Given this list of marker genes Gm36584, Or6f1, Cfap161, Vmn2r-ps67, Gm6112, Bnc1, Zfp592, Gm18806, Vmn2r-ps84, Sh3gl3, Gm7964, Gm22177, Gm6230, Vmn2r-ps72, Vmn2r-ps76, Tmc3, Or14a259, E230029C05Rik, Vmn2r66, Gm44968, Zscan2, Ctxnd1, Gm26708, Vmn2r-ps79, Gm19203, Fsd2, Rab38, Homer2, Vmn2r-ps73, Vmn2r-ps78, Or5ae1, Or14c43, Me3, Efl1, 4933406J10Rik, Gm18358, Vmn2r78, Tprgl-ps1, Folh1, Or14a258, Vmn2r-ps66, Vmn2r79 (vomeronasal 2, receptor 79), Gm6240, 2310044K18Rik, Or14c45, Tmem135, Or5ae2, Grm5, 2900076A07Rik, Il16 (interleukin 16), Gm32850, Or14c41, Gm18359, Or14c44, Phgdh-ps1, Vmn2r-ps82, Vmn2r71, Vmn2r67 (vomeronasal 2, receptor 67), Slc28a1 (NCBI Gene Id 434203), Iqgap1, Alpk3, Adamtsl3, Vmn2r-ps87, Gm22934, AI314278, 2610206C17Rik, 5930435M05Rik, Vmn2r-ps86, Vmn2r-ps62, Btbd1, Arnt2 (NCBI Gene Id 11864), Gm15661, Fah, Gm7957, Gm15744, Gm15880, Saxo2, Vmn2r-ps80 (vomeronasal 2, receptor, pseudogene 80), Cpeb1os1, A530021J07Rik, Gm30873, Gm25345, Cpeb1, Hdgfl3, Or14a256, Or14c40, Rps13-ps2 (NCBI Gene Id 100039924), Zfand6, Vmn2r73, Prss23os, Tyr, Rps17, Vmn2r-ps69, Vmn2r76, Vmn2r-ps81, Vmn2r77, Vmn2r-ps75, Sec11a, Wdr73, Mex3b, Or14n1-ps1, Vmn2r-ps64, Tprgl-ps2, Crtc3, Gm18360, Gm39043, Gm17919, Ndufs6b, Gm44827, Vmn2r70, A230065N10Rik, Or14a260, Gm8183, Rpl7a-ps9, Abhd17c, Or6aa1, Vmn2r72, 3110009M11Rik, Gm2546, Gm7180, Nox4, Eed, Btf3-ps5, Fzd4 (frizzled class receptor 4), 4933430H16Rik, Vmn2r74, Ap3b2, Vmn2r-ps65, Gm20744, Or14a257, Vmn2r68 (vomeronasal 2, receptor 68), 1700010L04Rik, Or14c39, Gm16638, Hikeshi, Or14o1-ps1, Tm6sf1, Vmn2r-ps68, Vmn2r69, Gm10610, Gm18560, BC048679, Ccdc81, Gm44570, Picalm, Vmn2r-ps85, Vmn2r-ps70, Cemip, Ctsc (NCBI Gene Id 13032), Whamm (WAS protein homolog associated with actin, golgi membranes and microtubules), Or14c46, Mir1839, Vmn2r65, Or13g1, Vmn2r-ps83, Nmb, Gm18354, Ramac, Vmn2r-ps77, Gm6155, Or14c42-ps1, Gm24249, Vmn2r75, Tlnrd1, Prss23, Pde8a, 2310010J17Rik, Gm18779, 3110040N11Rik, Mesd, Gm18782, Stard5, here is a description of the gene set: Mouse Gene Set: chr7D3 species: Mus musculus